The following is a description of a gene set: The ternary complex factor Net/Elk3 is downregulated in hypoxia and participates in the induction by hypoxia of several genes, including c-fos, vascular endothelial growth factor and egr-1. However, the global role of Net in hypoxia remains to be elucidated. We have identified, in a large-scale analysis of RNA expression using microarrays, more than genes that are regulated by Net in hypoxia. In order to gain insights into the role of Net in hypoxia, we have analysed in parallel the genes regulated by HIF-1alpha, the classical factor involved in the response to hypoxia. We identified about genes that are regulated by HIF-1alpha in hypoxia. Surprisingly, when we compare the genes induced by hypoxia that require either Net or HIF-1alpha, the majority are the same (75%), suggesting that the functions of both factors are closely linked. Interestingly, in hypoxia, Net regulates the expression of several genes known to control HIF-1alpha stability, including PHD2, PHD3 and Siah2, suggesting that Net regulates the stability of HIF-1alpha. We found that inhibition of Net by RNAi leads to decreased HIF-1alpha expression at the protein level in hypoxia. These results indicate that Net participates in the transcriptional response to hypoxia by regulation of HIF-1alpha protein stability. studied in species Mus musculus Genes down-regulated in SEND cells (skin endothelium) at hypoxia after knockdown of ELK3 and HIF1A by RNAi. from publication Gross C, Dubois-Pot H, Wasylyk B (PMID 17704799) Mouse Gene Set: GROSS_HYPOXIA_VIA_ELK3_AND_HIF1A_DN, and this is the list of marker genes: Cdc25a, Amd2, Sac3d1, Plec, Txnip, Rcc2, Tardbp, H2aj, Tex30, Cacna1h, Fas, Prpf19, Cd276, Mmp8, Lgals3bp, Nsl1, Arl4c, Bmp4, Tk2, Gna11, Cpd (carboxypeptidase D), F2r, Plxna1, Acp1, Agrn, Cacybp, Ccnb1, Setd7, Tns1, Gadd45g, Irgm1, Sephs2, Lztr1, Ccnd1, Il18, Mgat4b, Exo1, Gart, Srsf7, Srsf2, Usp46, Get1, Ifngr2, Map3k11, Notch1, Lpcat1, Pmp22, Ube2c, Ssbp3, Il1r1, Rapgef3, Elovl6, Stxbp5, Ssh1, Atp1b3, Nrarp, Ppat, G3bp1, Srsf10, Rad23b, Kpna2, Mogs, Cdk2ap1, Frrs1, Dido1, Mat2a, Trim21, Myh9, Lilrb4b (NCBI Gene Id 14727), Ly6a, Srsf1, Tbc1d1, Zmat3, Nherf1, Sgo1, Tmem176a, Chn2, Dusp7, Mgat2, Hacd3, Lsm2, Akap8, Rad1, Rrm2, Bcl6b, Amd1, Rxra, Hoxb7, Sigmar1, Col4a2, H6pd, Skil, Casp3, Apln, Elovl1, Frzb, Ifi30, Gata2, Topbp1, Ifit1, Tnrc6a, Pycr2, Camkk2, Ets2, Srsf5, Cds2